Given this list of marker genes PUM1, DHX58, ZC3HAV1, ZCCHC3, TRIM15, OASL, USP17L2, HDAC6, DDX60, PUM2, ANKRD17, USP15, here is a description of the gene set: Human Gene Set: GOBP_POSITIVE_REGULATION_OF_RIG_I_SIGNALING_PATHWAY Any process that activates or increases the frequency, rate or extent of RIG-I signaling pathway. species: Homo sapiens